The following is a description of a gene set: species: Homo sapiens Genes having at least one occurence of the motif CCCACAT in their 3' untranslated region. The motif represents putative target (that is, seed match) of human mature miRNA hsa-miR-299-3p (v7.1 miRBase). Human Gene Set: CCCACAT_MIR2993P, and this is the list of marker genes: TCF4, PPME1, RABEPK (Rab9 effector protein with kelch motifs), PAXIP1 (NCBI Gene Id 22976), CNNM4, AGBL5, PDLIM2, KIRREL3-AS3 (NCBI Gene Id 283165), PARP6, ITGAV, CUX1, PDZD11, ACACA, BCL11A, KLHL17, GIT1 (GIT ArfGAP 1), ADD1, APBB3, CD164, UBE2H, FOXP4, MAPRE3, TRPM3, TIMP3, ZNF207, IFIT1, AP1G1, TOP1, IQSEC2, VEGFA (vascular endothelial growth factor A), PLEKHH2, WDR81, XKR7, RAB6C (NCBI Gene Id 84084), CHST2, FBXO33, SMC1A, LUC7L3, NGFR, KCNMA1 (NCBI Gene Id 3778), MUC4, EPHA7 (NCBI Gene Id 2045), RUNX1T1, ABTB3, CYB5R3, SP4, RNF43, ZNFX1, ABCE1, RAB6A, CDC42, NDST1, ARRDC3 (NCBI Gene Id 57561), TMEM35A